Given this list of marker genes F5, ITGB3, RBM8A, FGB, F2, ITGA2B, FGA, MCFD2, F13B, F13A1, LMAN1, FGG, F8, here is a description of the gene set: studied in species Homo sapiens Human Gene Set: HP_PROLONGED_BLEEDING_FOLLOWING_CIRCUMCISION Prolonged bleeding following circumcision Bleeding that persists for a longer than usual time following circumcision.